Given this list of marker genes Akap12, Gbp7, Gstm1, Calr, B2m, H2-Eb1, H2-DMb1, H2-Aa, Ccnl1, Hilpda, Tm4sf1, Ifitm3, Trim37, Psme2, Sema3c, Klf6, Ccnd2, Aldh2, Nsg1, Elf1, Wasf2, Rpl13a, Dusp8, Dll1, Rps5, Cryab, Plaat3, Vwf, Hsp90ab1, Tnfsf10, Klf4, Pnrc1, Ier3, Bcl6b, Plscr2, Scgb1a1, Spag7, Palmd, Emp3 (epithelial membrane protein 3), Jam2, Edn1, Psmb9, Lrrc32, Gapdh, Rbm25, Spag9, Enpp4, Gstm2, Isg15, Syne1, Tle5, Rpl18a, Gpr182, Aldoa, Klf2, Ifit3, H2-T23, Rps3, Arid5a, Ntrk2, Car14, Tmem252, Ctnna1, H2-K1, Smad7, Dusp6 (NCBI Gene Id 67603), Zfp36l1, Nfib, H2-Q4, Pcp4l1, Rpl8, Tspo, Psmb8, Lima1, Sox17, Cfl1, H2-Ab1, Vegfa, Tspan8, Sox7, Ly6a, Fxyd5, Srgn, Gbp4, Igtp (interferon gamma induced GTPase), Rpl13, Slc6a6, Sp110, Gbp2, Tap1, Cd74, Xist, Pdlim1 (PDZ and LIM domain 1 (elfin)), Crip1, Iigp1c, Cebpd, Pde4b, Ptprb, Prss23, Lrg1, Klf3, Plac8, Sf3b2, Cemip2, Adamts1, Nrarp, Srsf7, Pkm, Rpl22l1, Mmrn2, Rpsa, Rhoc, Jund, Upp1 (NCBI Gene Id 22271), Tgm2, Rps20, Ifi47, Gja4, Depp1, Adk, Ccl5, Anxa2, Cd9, Cxcl12, Ly6c1, Cdk19, Cldn5 (claudin 5), Fam110d, Lxn, Hsp90aa1, Clic4, Nr4a1, Psmb10, Cdkn1a, Nfe2l2, Gstp1, H2-D1, Adam15, Pcm1, H2-DMa, Alas1, Ifitm2, Atf3, Tinagl1, Clic1, Aqp1, Tmod2, Prr13, Flt1, here is a description of the gene set: Mouse Gene Set: TABULA_MURIS_SENIS_LUNG_BRONCHIAL_SMOOTH_MUSCLE_CELL_AGEING species: Mus musculus from publication Tabula Muris Consortium (PMID 32669714)